Given this list of marker genes TGM1, SDCBP2, AMER2, TPTE2P1, AEN (apoptosis enhancing nuclease), RNF150, STARD4, CRLF2, ADM, PURPL, LGALS12, MECP2, PRKAB1, WRAP53, CCDC144A, CCDC107, RRAGD (NCBI Gene Id 58528), TFPI, CABP7, B3GNT4, ADGRE2, SH2B2, NTMT1, ANKRD37, H4C2, PLEKHF1, TLCD3A, SPINDOC, SLC16A3, RHOJ, PLEK2 (pleckstrin 2), PERP, PPM1D, MAMLD1 (mastermind like domain containing 1), TESK1, ZNF787, CCDC38, TUBA4B, RUNDC3B, FADS1, ENSG00000229727, SPTLC3, LMOD3, ATF3, GNA15, LINC01949, IL2, CST11, SNHG7, FBXO24, MCOLN1, BGLAP, TNFRSF11A, DOK1, FBXO42, PARD6A, ZMAT3, PRRX2, NLRP8, SLC25A41, CSRP2, ADGRG3, H2AC14, BAX, SDC4, GADD45A, STARD10, LINC00635, SH2D2A, KIAA2012-AS1, KCND1, NEU1, PBX4, LYL1, CPN1, LGALS4, PFKFB4, HMOX1, KLHL14, NARF, DEFB125 (NCBI Gene Id 245938), ZNF540, IER5, CD70, NUBP2, TNFRSF10D, NMB, FUT8-AS1, NRARP, TMEM120A, RASSF7, RAMP2-AS1, GPR68, LINC00479, MTCL2, STPG1, ZNF71, DKK2, VEGFA, ZNF79, PFKP, ADAMTS19, COQ7, RAB20, RHBDD1, ANKRD30A, SLC35G3, LINC00698, MIR663AHG, GPR137, SCARB1, INHA, CTNNAL1, ENO1, PRND, TRIAP1, HILPDA, MDM2, ZNF354B, POM121L9P, PHLDA3, AK4, CSF3, VNN3P, GTF2IRD1, SLC2A1, ASPA, PHPT1, RNF227, C2CD6, OR4C1P, LRRC75B, ALDOC, PPM1A, LINC03019, PCLAF, ENO2, RBPMS, FBXO22, LRRC39, EBF1, GPI, ORC6, IPO11, MAFG, BNIP3, P4HA1, SYTL3, MXI1, YPEL4, AURKA, LPAR4, MMP2, KCNK5, SCARNA2, MIP, TRAPPC3L, ZNF341, HIPK3, SLC25A51 (solute carrier family 25 member 51), LCNL1, TNFSF4, PUSL1, DHH, OLR1, TBCD, PHF21B (PHD finger protein 21B), HAS1, DTNB, DUSP3, FDXR, GAPDH (NCBI Gene Id 2597), PCNA, GRAP2, SCN2B, P2RY2, DHRS3, DDX59, KRTAP2-4, EYA2, PHLDA1 (pleckstrin homology like domain family A member 1), AFDN-DT, TAAR5 (trace amine associated receptor 5), LINC03103, TNFRSF10B (TNF receptor superfamily member 10b), DDB2, ATP9A, TIGAR, ZNF581 (zinc finger protein 581), TPI1, FHL2, OSM, here is a description of the gene set: Human Gene Set: GSE16450_CTRL_VS_IFNA_12H_STIM_IMMATURE_NEURON_CELL_LINE_DN studied in species Homo sapiens from publication Peltier DC, Simms A, Farmer JR, Miller DJ (PMID 20483728) Genes down-regulated in immature neuron cell line: control versus interferon alpha (12h). Human neuronal differentiation alters responsiveness to innate immune stimuli and virus infections. We used microarrays to examine the transcriptional responses of the human BE(2)-C neuroblastoma cell line to retinoic acid-induced differentiation and type I IFN stimulation.